Given this list of marker genes AMD1, SSX2, SEC24A, CBX4, DLG1, SOD2, RSL1D1, MX2, GK, ELANE, MARK2, CXCL10, GNB3, TFRC, PTPN21, RAP2A, KPNA5, RBM38, ACSM1, CCNE1, LYZ, RHO (NCBI Gene Id 6010), HSPA13, DPT, GRIA1, RCC1, N4BP2L1, IGFBP2, NR4A3, RSRP1, CDR2, PCDHGA12, ERF, WASL, ZNF264, MAX, RBBP6 (NCBI Gene Id 84712), PPFIA1, GDF11, PLA2G4A, GPX3, CALM1, TGFBR1, NASP, DNAJA1, PIM2, STAT5B, SFPQ, PROX1, FGF18, COL21A1, UBE2G1, TSFM (Ts translation elongation factor, mitochondrial), GNS, SPOCK1, PAGE1, SAMHD1, APOE, DDX3X, DDAH1 (NCBI Gene Id 23576), EFNB2 (NCBI Gene Id 1948), GABPA, TNFAIP6, HSPA1A, AOC2, OAS2, HSPA12A, TLL2, CRY1, GNA13, OCLNP1, DBF4, ABCA6, ICAM1, PLAAT4, RBBP5, KHDC4, TNFSF10, WT1-AS, BTF3P12, SNHG3, RB1, AKAP8L, ZNF35, PLCL1, NPTX2, DNAJB1, RHOB, PTPN11 (protein tyrosine phosphatase non-receptor type 11, NCBI Gene Id 84990), BLNK, CSPG5, ISG20, IRF4, FOS, RAB5A, FNBP4, CRKL, GALNT3, ABCC5, DUSP8 (NCBI Gene Id 1850), H2AX, OAS1, KITLG, GPC1-AS1, EIF5, here is a description of the gene set: from publication Browne EP, Wing B, Coleman D, Shenk T (PMID 11711622) The effect of human cytomegalovirus (HCMV) infection on cellular mRNA accumulation was analyzed by gene chip technology. During a 48-h time course after infection of human diploid fibroblasts, 1,425 cellular mRNAs were found to be up-regulated or down-regulated by threefold or greater in at least two consecutive time points. Several classes of genes were prominently affected, including interferon response genes, cell cycle regulators, apoptosis regulators, inflammatory pathway genes, and immune regulators. The number of mRNAs that were up-regulated or down-regulated were roughly equal over the complete time course. However, for the first 8 h after infection, the number of up-regulated mRNAs was significantly less than the number of down-regulated mRNAs. By analyzing the mRNA expression profile of cells infected in the presence of cycloheximide, it was found that a minimum of 25 mRNAs were modulated by HCMV in the absence of protein synthesis. These included mRNAs encoded by a small number of interferon-responsive genes, as well as beta interferon itself. Cellular mRNA levels in cytomegalovirus-infected cells were compared to the levels in cells infected with UV-inactivated virus. The inactivated virus caused the up-regulation of a much greater number of mRNAs, many of which encoded proteins with antiviral roles, such as interferon-responsive genes and proinflammatory cytokines. These data argue that one or more newly synthesized viral gene products block the induction of antiviral pathways that are triggered by HCMV binding and entry. Genes up-regulated in primary fibroblast cell culture point after infection with HCMV (AD169 strain) at 8 h time point that were not up-regulated at the previous time point, 6 h. Human Gene Set: BROWNE_HCMV_INFECTION_8HR_UP species: Homo sapiens